The following is a description of a gene set: The process in which a relatively unspecialized cell acquires the specialized features of an astrocyte. An astrocyte is the most abundant type of glial cell. Astrocytes provide support for neurons and regulate the environment in which they function. Human Gene Set: GOBP_ASTROCYTE_DIFFERENTIATION studied in species Homo sapiens, and this is the list of marker genes: MAPK3, GCM1, CUL4B, BIN1, NR2E1, MAPT, MIR181B1, F2, HMGA2, MIR181C, STAT3, EPHA4, CLCF1, S100B, MAG, FPR2, IL6, CNTF, EOMES, NF1, PAX6, POU3F2, VPS54, HES5, TAL1, CNTN2 (contactin 2), MYCN, TSPAN2, HES1, IL6ST, NOG, GFAP, ID4, NKX2-2, S100A8, MAPK1, LDLR, ADORA2A, IL1B, NR1D1, LAMC3, TTBK1, IFNGR1, QKI, TTC21B, MAP2K1, GAP43, ID2, VIM, SOX8, GRN, ABL1, DAB1, SERPINE2, PTPN11, TLR4, NTRK3, SOX9, EIF2B5 (NCBI Gene Id 8893), SHH, ZEB2, VAX1, DRD1, MIR142, KRAS, PLPP3, AGER, LIF, MFSD8, BMP2 (bone morphogenetic protein 2), C1QA, LAMB2, DLL1, CDK6, PLP1, APP, IFNG, SMO, TREM2 (triggering receptor expressed on myeloid cells 2), NR3C1, C5AR1, GPR37L1, S100A9, NAGLU, ROR1, PSEN1, LRP1, LARGE1, TNF, NOTCH1